Given this list of marker genes Mapk11, Tab1, Rps27a, Ppp2r1b, Dusp7, Map3k8, Map2k3 (NCBI Gene Id 26397), Mapk7, Ube2v1, Ppp2r5d, Ube2n, Tab3 (NCBI Gene Id 66724), Nfkb1, Rps6ka5, Ubb, Map2k4, Mapk14, Vrk3, Mapk9, Ikbkb (inhibitor of kappaB kinase beta), Fos (FBJ osteosarcoma oncogene), Mapk8, Map2k7, Tab2, Jun, Cul1, Mapk3, Map2k6, Irak1, Dusp6, here is a description of the gene set: part of: Signaling by Interleukins electronically inferred by orthology from the curated human pathway This event has been computationally inferred from an event that has been demonstrated in another species.<p>The inference is based on the homology mapping from PANTHER. Briefly, reactions for which all involved PhysicalEntities (in input, output and catalyst) have a mapped orthologue/paralogue (for complexes at least 75% of components must have a mapping) are inferred to the other species. studied in species Mus musculus Reactome Pathway: Interleukin-17 signaling